Given this list of marker genes Sparc, Vwa7, Emilin2, Fbn2, Zp2, Spon1, Tnxb, Cilp2, Crispld2, Fndc7, Kcp, Coch, Emid1, Cthrc1 (NCBI Gene Id 68588), Ntn1, Tgfbi, Igfbp6, Ltbp4, Zp3, Matn1, Tnn, Zp3r, Fbln7, Ambn, Tecta, Nid1, Mfge8, Lama3, Creld1, Vwa5b1, Ecm1, Crispld1, Oit3, Sspo, Slit2, Eln, Zp1, Igfbp7, Nell1, Bsph1, Vwa2, Mfap4, Mfap2 (NCBI Gene Id 17150), Egflam, Igfbp3, Fbln2, Ints14, Slit3 (slit guidance ligand 3), Amelx, Lamc1, Crim1, Fga, Igfals, Ndnf (neuron-derived neurotrophic factor), Ccn1 (cellular communication network factor 1), Ccn6, Ntng2, Edil3, Mfap5, Vit, Efemp1, Lama1, Sbspon, Mgp, Ibsp, Cdcp2, Papln, Fndc1, Nid2, Thbs2, Egfem1, Lrg1, Vwf, Ccn3, Matn4, Tspear, Vtn, Thbs1, Lgi3, Npnt, Otol1, Fbln1, Mfap1b, Vwa1, Fn1, Agrn, Colq, Bsph2, Gldn, Igsf10, Ntn5, Spon2, Lamb3, Tsku, Lgi2, Vwa3a, Smoc1, Hmcn1, Emilin3, Srpx2 (NCBI Gene Id 68792), Vwce (von Willebrand factor C and EGF domains), Zpld1, Ltbp2, Fgl2, Mmrn2, Vwa5a, Matn2, Pcolce2, Fbln5, Adipoq, Igfbp5, Bglap3, Thsd4, Otog, Lamb1, Vwa3b, Bmper, Lamc2, Comp, Pxdn, Rspo4, Ccn2, Vwde, Nell2, Gas6, Lama5, AW551984, Fndc8, Cilp (NCBI Gene Id 214425), Pcolce, Bglap2, Ecm2, Lgi4, Aebp1, Tinag, Igfbpl1, Sned1, Igfbp1, Abi3bp, Srpx, Spp1, Hmcn2, Mepe, Dpt, Ntng1, Fgl1, Lamc3, Reln, Ints6l, Fgg, Mfap3, Lamb2, Ltbp1, Slamf6, Smoc2, Vwa5b2, Ltbp3, Cdcp3, Thbs4, Dspp, Fgb, Dmp1, Mfap1a, Lgi1, Lama4 (laminin, alpha 4), Tinagl1, Tnc, Lama2 (NCBI Gene Id 215870), Ntn3, Mmrn1, Rspo1, Postn, Svep1, Matn3, Tnfaip6, Efemp2, Ccn4, Dmbt1, Igfbp4, Ccn5, Rspo3, Slit1, Creld2, Emilin1, Thbs3, Otogl, Igfbp2, Ntn4, Rspo2, Fbn1, Tnr, Sparcl1, Fras1, Tectb, here is a description of the gene set: Mouse Gene Set: NABA_ECM_GLYCOPROTEINS One hallmark of ECM proteins is their domain-based structure. Exploiting this characteristic, we established a list of diagnostic InterPro domains commonly found in ECM proteins. We know that some of the domains used to select positively for ECM proteins are also found in transmembrane receptors and proteins involved in cell adhesion (growth factor receptors, integrins, etc) that do not belong to the ECM. These families of proteins also display a subset of specific domains and transmembrane domains incompatible with definition as from publication Naba A, Clauser KR, Hoersch S, Liu H, Carr SA, Hynes RO (PMID 22159717) Genes encoding structural ECM glycoproteins species: Mus musculus